Given this list of marker genes METTL8, DUSP22, BCAS4, FCRL2, MACROD2, FCRL1, GPM6A, TPD52 (NCBI Gene Id 7163), PLPP5, LY9, HVCN1, CNR2, BAIAP3, STX7, COBLL1, CD70, COL4A3, LINC00926, AK8, GNG7, HLA-DOB, DRAM2, TBC1D9, BTLA, CD180, OSBPL10-AS1, RAB30, PKHD1L1, LINC02422, COL19A1, PLEKHG7, CYSLTR1, FCRLA, MEF2C, GGA2, ZDHHC21, ENSG00000230709, TMEM156, IKZF3, FCRL3, BTNL9, PNOC, NCOA3, GNB5, SPON1, CLECL1P, CXXC5, EZR, GNG3, CYB561A3, TNFRSF13B, LINC02397, OSBPL10, TLR10, NFKBID, RALGPS2, LINC00494, FCGR2B, CD83, E2F5, PTPN1, OSTN-AS1, LINC02413, VOPP1, ZNF860, CD19, SP100, SYNPO, TCOF1, STAP1, TMEM154, NXPH4, ARHGAP24, CD52, ABCB4, HLA-DOA (NCBI Gene Id 51034), ISCU, TRAF5, CD22, SWAP70, CD37, LARGE2, MARCHF1, EBI3, DOK7, CXCR5, COL4A4, ORAI2, AP1S3, P2RX5, SP110, CNTNAP2, TEX9, SPIB, TNFRSF13C, SLC38A11, REL, IFT57, MS4A1, SETBP1, AIM2, ADAM19, CNFN, PRDM2, TFEB, KDM4B (NCBI Gene Id 23030), SMIM14 (small integral membrane protein 14), PPM1K (protein phosphatase, Mg2+/Mn2+ dependent 1K), LINC01857, RPS11, PEG10, SMAGP, CPNE5, BANK1, RHBDF2, FXYD1, CD79A, ZBTB32, SEL1L3, SP140, PLEKHG1, ARHGAP25, LARGE1, PNISR, BLK, LIMS2, ADAM28, FCMR, ACP5, CHD7, RRAS2, FCER2, LINC01781, COCH, NFKB2, KLK1, COL9A3, BIRC3, BACE2, CD40, LCN8, SEMA4B, here is a description of the gene set: species: Homo sapiens Human Gene Set: HAY_BONE_MARROW_FOLLICULAR_B_CELL from publication Hay SB, Ferchen K, Chetal K, Grimes HL, Salomonis N (PMID 30243574)